Given this list of marker genes Mir214, Akt2, Mapk14, Map2k7, Map2k6, Dvl1, Chuk, Pik3cb, Edn1, Mir133a-2, Raf1, Prkcb, Map2k3, Mirlet7b, Mapk8, Pik3r3, Rcan1, Wnt3a, Mir30f, Pik3r2, Map2k5, Igf1r, Map3k14, Cish, Ikbke, Wnt5a, Tnf, Lrp5, Pdpk1 (3-phosphoinositide dependent protein kinase 1), Rock1, Rock2, Fgfr2, Tab1, Myef2, Lif, Mapk7, Cdk7, Il6st, Mylk3, Mir15b, Pla2g2a, Hdac7, Egf, Nfatc4, Nppa, Nrg1, Prkg1, Eif2b5, Ppp3ca, Mir103-2, Ppp3cb, Map2k4, Pik3cd, Mylk, Plcb2, Mir133b, Mapk1 (mitogen-activated protein kinase 1), Fgf2, Fzd2 (frizzled class receptor 2), Mir125b-1, Ikbkg (inhibitor of kappaB kinase gamma), Mir130b, Camk2d, Mir103-1, Mir30e, Mir140, Hdac5, Mir199a-2, Nppb (NCBI Gene Id 99970), Mapk4, Pik3cg, Mir185, Map2k1, Mir21a, Stat3, Hdac4, Mtor, Ctnnb1, Hdac9, Fzd1, Tgfb1, Rhoa, Rac1, Akt1, Mir27b, Gsk3b (glycogen synthase kinase 3 beta), Igf1, Nfkb1, Pik3ca (phosphatidylinositol-4,5-bisphosphate 3-kinase catalytic subunit alpha), Gata4, Map2k2, Ikbkb, Agt, Cdk9, Lrp6, Pik3r1, Calm1, Mir133a-1, Mapk3, Ctf1, here is a description of the gene set: Mouse Gene Set: WP_MICRORNAS_IN_CARDIOMYOCYTE_HYPERTROPHY MicroRNAs in cardiomyocyte hypertrophy species: Mus musculus